Given this list of marker genes SPAAR, ATP6V1G2, ATP6AP2, CCDC115, ATP6V0D1 (NCBI Gene Id 9114), ATP6V0A1, ATP6V1F (NCBI Gene Id 9296), TCIRG1, ATP6AP1, ATP6V1A, ATP6V1D, ATP6V1C2, ATP6V0D2, ATP6V1C1 (NCBI Gene Id 528), ATP6V1B2, ATP6V1G1, ATP6V0E2, ATP6V0C, ATP6V0A2, ATP6V1B1, RNASEK, TMEM199, ATP6V0A4, ATP6V1G3, ATP6V0E1, ATP6V1H, ATP6V1E1, ATP6V0B, here is a description of the gene set: studied in species Homo sapiens A proton-transporting two-sector ATPase complex that couples ATP hydrolysis to the transport of protons across a concentration gradient. The resulting transmembrane electrochemical potential of H+ is used to drive a variety of (i) secondary active transport systems via H+-dependent symporters and antiporters and (ii) channel-mediated transport systems. The complex comprises a membrane sector (V0) that carries out proton transport and a cytoplasmic compartment sector (V1) that catalyzes ATP hydrolysis. V-type ATPases are found in the membranes of organelles such as vacuoles, endosomes, and lysosomes, and in the plasma membrane. Human Gene Set: GOCC_PROTON_TRANSPORTING_V_TYPE_ATPASE_COMPLEX